Given this list of marker genes PDCD6IP, VPS4A (vacuolar protein sorting 4 homolog A), VPS4B, CHMP4C, CHMP4B, here is a description of the gene set: Human Gene Set: GOBP_UBIQUITIN_INDEPENDENT_PROTEIN_CATABOLIC_PROCESS_VIA_THE_MULTIVESICULAR_BODY_SORTING_PATHWAY species: Homo sapiens The chemical reactions and pathways resulting in the breakdown of a protein or peptide, via the multivesicular body (MVB) sorting pathway; proteins are sorted into MVBs, and delivered to a lysosome/vacuole for degradation. This process is independent of ubiquitination.